The following is a description of a gene set: studied in species Homo sapiens Human Gene Set: HP_ABNORMAL_CIRCULATING_ORGANIC_COMPOUND_CONCENTRATION Any deviation of the concentration of an orrganic compound from the normal range. An organic compound is defined as any compound that contains a carbon atom. Abnormal circulating organic compound concentration, and this is the list of marker genes: RTL1, TARS2, PLA2G4A, C1GALT1C1, GATM, FARSA, TWNK, STX11, LYST, ALG5, BCO1, WRN, BCKDK, FOCAD, UMOD, SLCO1B1, HS6ST2, BCS1L, NDUFS1, MT-TV, GHR, DNAJC19, DYRK1B, PLAU, MTR, TCN2, PCCA, NDUFS2, MAGEL2, UPB1, SLC26A4, EPB42, PIEZO1, RFX6, JAG1, TYMP, HPD, GLA, DNAJB11, ACADVL, PEX7, NKX2-5, CPT1A, ARG1, RHAG, SLC2A2, ITPR3 (inositol 1,4,5-trisphosphate receptor type 3), PRKCSH, NUBPL, MT-TW, NDUFB11, MOCS2, FH, NDUFV1, NPHP1 (NCBI Gene Id 4867), PNPLA6, CHD8, AKR1D1, TAFAZZIN, GANAB, TEFM, MUTYH, BBIP1, DNM1L, TMEM126B, MT-TF, ANK1, MPC1 (NCBI Gene Id 51660), GAMT, SPTB, EFL1, NDUFV2, DCDC2, PKLR, NDUFB3, GCDH, HTT, MMP1, FAN1, LIPT1, SLC37A4 (solute carrier family 37 member 4), RHD, MT-ATP6, CCND1, COL4A3, IFT56, AASS, NDUFAF1, IYD, CPS1, GPX1, PNPLA8, SLC25A42, DUOXA2, KIF23, VPS50, PEX6, ETFDH, MAT1A, NAA10, TALDO1, GOT2, CYP7A1, HNF1B, GRHPR, SCARB2, PRPS1, FBXL4, SCAPER, TSHR, POLG2, FLCN, APOA1, APOC3, RHCE, LYN, SCP2, ALDH4A1, IQSEC2, MICU1, MTHFR, SERPINF1, PTPN22, SBDS, FHL1, NDUFB9, SC5D, PIGT, PLVAP, KLF1, PWRN1, MMEL1, NCF1, POLG, RAI1, DZIP1L, CYP11A1, MTX2, ALG9, BUD23, NHLRC2, DGAT1, INSR, DHCR24, PNPLA2, MLIP, NDUFS4, MDH1, BCKDHA, SUCLG1, SLC2A3, CHEK2, DPYS, TMEM270, BBS1, PHKA2, MYO5A, KARS1, PIGH, SLC2A9, PGM2L1, ABCA1, OSTM1, STX5, GPIHBP1, SLC25A13 (solute carrier family 25 member 13), ABCC8, ALAS2, COL7A1, KMT2D, NUP107, PDP1, CFB, SLC7A7, IRF6 (NCBI Gene Id 7452), VPS37D, BTD, PGK1, CYP19A1, SLCO1B3, PCK1, GLUL, PAFAH1B1, MTTP, CELA2A, ABCD4, LDHA, IL12A, NFE2L2 (NFE2 like bZIP transcription factor 2), HNF1A, PCYT1A, PEX10, GPHN, COX8A, RRM2B, HBB, PCSK9, MMADHC, ATP5F1A, ETFB, ELN, SLC6A19, LMNA, PAH, INVS, CEP19, NDUFAF6, NFS1, LMNB2, TSFM, TBCK, HADHA, PCBD1, CIDEC, OTC, BBS7, HSD17B10, PYGM, AVPR2, MKRN3 (makorin ring finger protein 3), CFHR1, PPP1R17, FLT1, SLC30A10, PWAR1, PIK3CG, SMARCAL1, ABCD1, NSDHL, IDH2, MUC1, BCAT2, MSMO1 (NCBI Gene Id 6307), PNP, ACADS, ABCG5, GALNT2, POLD1, BBS5, PKD1, TANGO2, PSMB8, NT5E, OAT, ETFA, TKT, TRMT10C, DIO1, CC2D2A, FECH, AMACR, NR4A2, CA5A, WDR35, GALT, TCEAL1, SLC5A5, MRM2, PHYH, MMACHC (NCBI Gene Id 25974), IBA57, GTF2I, ERCC6, IFT140, APOB, ACAD9, GLDC, PSMB4, SLC19A1, APRT, APP, ADCY3, TREX1, ALG6, CD46, IL6, COG4, TMEM70, FBN1, TBL2, DNAJC21 (NCBI Gene Id 134218), PPARG, ADK, NDUFA1, EIF2AK3, PDHA1, HCFC1, RAB27A, ACAD8, SNORD116-1, DMGDH, ARMC5, RFC2, LONP1, COX5A, ROBO1, SLC25A4, SLC6A6, ATP7B, TSHB, GCSH, MCM10, TDO2, PIK3R5, PHKB, DBH (NCBI Gene Id 1621), BBS2, ALG12, LMAN1, NDUFC2, NBAS, NR1H4, WDPCP, TTPA, MT-ND6, PFKM, AP1S1, HR, CTNS, BAAT, BAZ1B, ATP5MK, PEX5, DTYMK, GATA1, MEF2A (NCBI Gene Id 4205), MT-ND4, CLDN16, NGLY1, COX10, ATP8B1, GLS, EHHADH, BLVRA, MC4R, NOS3, MKS1, ATPAF2, BCKDHB, CAVIN1, ALDH5A1, MRPL3, NDUFAF2, MRPS22, EXTL3, SETX, SEC61A1, SLC6A8, GLRX5 (NCBI Gene Id 51218), MCCC2, SUGCT, HK1, MT-ND2, MT-TP, CYP27A1, GLUD1, REN, VARS2, APOC2, NPHS1, SLC25A36, SLC35C1, METTL27, BBS4, LRP6, GNAS, SEMA7A, DNAJC30, ABCA2, ALDOA, SMPD1, COQ9, NSMCE2, SLC41A1, LRPPRC, CYC1, TG, CFAP418, FLII, GTF2IRD2, AEBP1, POMC, HERC2, DLK1, SLC6A20, SLC25A15, CPT2, MT-TK, BMPR1A, PC, SLC29A3, PSAT1, SLC4A2, SLC35A2, SARDH, NAGS (NCBI Gene Id 162417), TNFRSF11B, DLD, UQCRC2, ASPA, NPHS2, MRPL39, PAX2, NFU1, TTC8, XDH, G6PC1, TNFRSF11A, PKD2, MYT1L, POU2AF1, UNC13D, MED12, GYS2, PTS, HLCS, KYNU, NDUFS3, PET117, MRPS14, PCCB, PEX12, SLC4A1, ATAD3A (ATPase family AAA domain containing 3A), LDLRAP1, CASK, LIPT2, UGT1A1, SDCCAG8, BBS9, SLC36A2 (solute carrier family 36 member 2), MT-ATP8, LBR, COX6A2, TJP2, ABCB7, PEX2, PKHD1, COQ7, NDUFA2, USP53, FOXE1, SLC52A1, ASS1 (argininosuccinate synthase 1), PNLIP (pancreatic lipase), GSR, ATP5F1D, MT-ND1, KCNN4 (NCBI Gene Id 3783), MTO1, CD320 (NCBI Gene Id 51293), UBE2A, PEX13, ELP1, OTX2, CDAN1, ZPR1, APOA5, ERCC8, SDHB, PEX16, GK (glycerol kinase), ADAMTS13, NKX2-1, KCNJ11, MT-TI, ALB, SLC22A5, OBSCN, IFT74, NDUFS8, BBS10, STOX1, ERCC4, CAV1, SEMA4A, ALMS1, OPA1, CLPX, ATP6AP1, HMBS, TMEM199, LMF1, SLC51B, TAT, NT5C3A, SERAC1, LZTFL1, PNPO, NDUFA11, BRCA2, PYGL, VPS33B, FTCD, SLC25A20, FOXRED1, WDR19, LYRM7, STX1A, PPOX, CNBP, MOCS1, HAVCR2, NDUFAF3, ALAD, SLC6A18, CARS2, ABCC2, TMEM260, SCLT1, GPR101, SPTBN1, CREB3L3, CAD, SYNE2, ATM, DEF6, MYO5B, CFHR3, AGL, SLC2A1, AIP, MMAB, L2HGDH, DCAF17, TNFRSF9, IFT172, ABCD3, SH2B1, POLR3A (NCBI Gene Id 11128), MTHFD1, MYC, COQ4, TBL1X, KCNJ1, POLE (DNA polymerase epsilon, catalytic subunit), GBA1, LPL, UQCRH, CORIN (corin, serine peptidase), IVD, MMAA, AR, MT-TL1, UNC45A, PDHB (pyruvate dehydrogenase E1 subunit beta), TFAM (transcription factor A, mitochondrial), SLC25A26, ABCB4, GALE, CPOX, MT-TE, TPO, SECISBP2, AP1B1, ZNF699, SORD (sorbitol dehydrogenase), XRCC4 (NCBI Gene Id 7518), ACSF3, RINT1, VIPAS39, GUCY2D, TUFM, IGF1, ETHE1, RPIA, ABCG8, QDPR, TMEM43, FAH, MCCC1, PHKG2, SEC63, APOE, DUOX2, ARL6, UROS, TRMU, CETP, ATAD1, CFI, TFG, TNPO3, HAL, ASNS, PEX3, LDLR, GALK1, PEX26, CEP290, KIF12, IARS1, GTF2IRD1, NPAP1, GLYCTK, OCRL, SNORD115-1, KDM1A, GALM, NDUFS6, ALDH18A1, ATP5F1B, SLC12A1, LIPA, ABHD5, APOA2, HADH, LTC4S, MCFD2, MKKS, ZMPSTE24, PLAAT3, C3, EMD, AMT, HSD17B4, PEX1, UROC1, UBR1, GNMT, DGUOK, PDHX (pyruvate dehydrogenase complex component X), CCDC47, BICC1, SKIC3, UBE3B, HNF4A, MRPS7, AHCY, GPD1 (glycerol-3-phosphate dehydrogenase 1), SCO2, XIAP, ACAT2 (NCBI Gene Id 39), DOLK, STXBP2, ABCB11, NDUFA6, TRIM32, EPHX2, GCH1, SPTA1, MARS1, LEP, GNPAT, LIG3, SLC10A1, MIPEP, RRAGC, SCO1, GYPC, DHCR7, ACTN4, CCDC115, ATP5F1E, ALG11, HMGCL, AIFM1, BSCL2, LMBRD1, PEX14, FBP1, MCEE (NCBI Gene Id 84693), SPR (sepiapterin reductase), ALDH6A1, MT-ND5, SYNE1, HPRT1, BOLA3, ALG8, PEX19, BCAP31, PITRM1, FKBP6, PRDX1, REPS1 (RALBP1 associated Eps domain containing 1), PEX11B, CCT5, IMPDH2, NDUFAF5, MT-ND3, SLC51A, RPS20, EBP, MPV17, PHGDH, FDFT1, SAR1B, TDP1 (NCBI Gene Id 55775, tyrosyl-DNA phosphodiesterase 1), CTH, ADRA2A, PLIN1, FARSB, THBD, TMEM67, ODC1, ACOX2, MRPS2, AKT2, FOS, YARS1 (tyrosyl-tRNA synthetase 1), HMGCS2, LIPE, TNFSF15, MPO, PAX8, LRP5, NADK2 (NAD kinase 2, mitochondrial), PSPH, RSPO1, CYP7B1, SARS2, COX6B1, ACADM, NDUFS7 (NCBI Gene Id 4727), LIMK1, PSMB10 (NCBI Gene Id 8138), ALDH7A1, SLC22A12, SPIB (Spi-B transcription factor), PRF1, COX16, PIGA, ACAT1, HADHB, MOCOS, MICOS13, APTX, UROD, NDUFAF4, LCAT, PNKP, ALDOB, MECP2, DEAF1, IRF5, NDUFAF8, SLC6A3, ASL, IL12RB1, RNU4ATAC, BBS12, PMM2, ANGPTL3, MEG3, CLIP2, RACGAP1, PRODH, UCP2, B4GALT1, SUCLA2, LEPR, G6PD, CBS, SLC17A5, PLA2G7, MTRR, CAV3, NDUFA13, NDUFB10, TIMMDC1, CFH (complement factor H), SGPL1, HSD3B7, LIPC, SLC34A1, IFT27, MMUT, EPB41, EIF4H, AGPAT2, PSAP, DCXR, PPM1K